The following is a description of a gene set: Mouse Gene Set: GOBP_ADENYLATE_CYCLASE_MODULATING_G_PROTEIN_COUPLED_RECEPTOR_SIGNALING_PATHWAY studied in species Mus musculus A G protein-coupled receptor signaling pathway in which the signal is transmitted via the activation or inhibition of adenylyl cyclase activity and a subsequent change in the intracellular concentration of cyclic AMP (cAMP)., and this is the list of marker genes: Rapgef2, Adgrf1, Gpr161, Vipr1, Adcyap1, Adcy3 (adenylate cyclase 3), Prkaca, Taar9, Chrm3, Adgrl2, Sstr5, Ucn2, Npb, Gpbar1, Pde2a, Ednra, Tshr, Pthlh, Gpr3, Akap12, Glp2r, Npy2r, Fpr-rs3, Adcyap1r1, S1pr2, Galr1, Adgre1, Adra2a, Ptgfr, S1pr1, Adcy4, Gpr146, Marco, Abca1, Prkar2b, Psap, Galr3, Adgrl1, Htr6, Ramp3, Nme2, Adgrf3, Adgrb3, Drd4, Hrh3, Mc4r, Adgrg3, Grm4, Gprc6a, Gnai3, Pth2r, Adgrd1, Gpr62, Adcy6, Calcrl, Mrgprd, Adra1a, Ptgdr2, Lpar2, Arrdc3, Tcp11, Cnr1, Adcy7, Grm3, Adcy9, Grm8, Or4m1, Grk2, Gnai1, Oprd1, Gper1, Drd3, Adgrf5, Iapp, Gpr157, Gna13 (guanine nucleotide binding protein, alpha 13), Grm6, Htr7, Sctr, Atp2b4, Ucn3, Adora2a, Cxcl11, Mgrn1, Pde10a (NCBI Gene Id 23984), Rgs2, Adgrg2, Nherf1, Adcy1, Gna14, Lhcgr, Ffar3, Nos1, Adora1, Ghrh, Grm2, Adrb2, Crtc3, S1pr4, Gipr, Agt, Fshr, Crhr1, Prkar1a, Htr1b, Oprm1, Mc3r, Gnat3, Rack1, App, Cxcl10, Adgrb1, Adrb1, Rln1, Grk5, Gna12, Itgb3, Gpr176, Ghrhr, Gnat2, Sstr4, Adm, Chrm5, Adcy8, Ptgir, Ptger1, Prkar2a, Adgrf4, Adgre5, Psapl1 (NCBI Gene Id 76943), Taar1, Akap5, Pde4d (phosphodiesterase 4D, cAMP specific), Dgkq, Rxfp1, Drd1, S1pr5, Taar7d, Mc5r, Gna15, Taar5, Vipr2 (vasoactive intestinal peptide receptor 2), Gnas, Pde4a, Adra1b, Adgrl3, Pth, Mas1, Chga, Adrb3, Palm, Adgrg5, Gpha2, Flna, Gnaq, Taar6, Fpr-rs6, Fpr2, Aplp1, Crhr2, Tbxa2r, Gpr6, Calcr, Prkacb, Gpr119, Gcgr, Ptger2, Lpar3, Gpr88, Pf4, Insl3, Gpr101, Fpr-rs4, Gpr4, Calca, Gabbr2, Drd2 (NCBI Gene Id 13489), Gpr12, Grm7, Cort, Gpr37l1, Adgrl4, Gnal, Ffar4, Gnat1, Or51e2, Gabbr1, Gpr26, Oprl1, Htr5b (NCBI Gene Id 226369), Pde3a, Cnr2, Ric8a, Rims2, Htr5a, Gpr171, Adgrg4 (adhesion G protein-coupled receptor G4), Ptger4, Gpr61 (G protein-coupled receptor 61), Aplnr, Gip, Gphb5, Chrm4, Ptger3, Lpar1, Vip, Htr1d, Oprk1, Gnao1, Rxfp2, Adcy5, Mc1r, Gsk3a, Pth1r, S1pr3, P2ry12 (purinergic receptor P2Y, G-protein coupled 12), Fpr-rs7, Chrm2, Gpr65 (NCBI Gene Id 14744), Edn1, Grik3, Adgrg1, Mrap (melanocortin 2 receptor accessory protein), Cacna1d, Prkar1b, Gpr37, P2ry1, Adgre4, Adgrb2, Adgrg7, Calcb, Pln, Cxcl9, Adgrf2, Sstr2, Npr3, Mc2r, Oxgr1, Prmt5, Cxcr3, Rapgef4, Htr1f, Casr, Glp1r, Rit2, Adora2b, Hrh4, Adgrg6, Sct, Adm2, Galr2, Gnaz, Adra1d, Ramp2 (receptor (calcitonin) activity modifying protein 2), Gcg, Htr1a, Mtnr1a, Pomc, Ramp1, Gna11, Tmem116, Gnai2, Htr4, Chrm1, Drd5, Adcy2 (adenylate cyclase 2), Mrap2